Given this list of marker genes LTBP4, AR, BIN1, SNUPN, SPG11, FHL1, MTMR14, KLHL9, VAPB, DNM2, MAP3K20, POMK, SGCD, FKRP, ITPR1, CAV3, SGCA (NCBI Gene Id 6442), ANO5 (NCBI Gene Id 203859), VPS13A, POMGNT1, MATR3, CAPN3, UNC45B, TRPV4, SACS, CHCHD10, TRIM32, KCNA1, FLNC, MYH7, POMGNT2, LAMA2, MYF6 (myogenic factor 6), DYSF, SGCB, POMT1, PLEC, PPARG, DPM3, SLC25A1, TTN, PMP22 (peripheral myelin protein 22), POPDC3, HMGCR, HINT1, POMT2, FRG1, DMD, LIMS2, SGCG, DAG1, RYR1 (NCBI Gene Id 906), CNBP, DHX16, FKTN, GMPPB, MICU1, PNPLA2, DES, CIDEC, SMN1, LARGE1, REEP1, WASHC5, NEB (nebulin), PLIN1, TCAP, FBN2, CRPPA, LMNA, here is a description of the gene set: Abnormal calf musculature morphology Human Gene Set: HP_ABNORMAL_CALF_MUSCULATURE_MORPHOLOGY studied in species Homo sapiens